The following is a description of a gene set: Human Gene Set: REACTOME_FATTY_ACIDS_BOUND_TO_GPR40_FFAR1_REGULATE_INSULIN_SECRETION Fatty Acids bound to GPR40 (FFAR1) regulate insulin secretion species: Homo sapiens, and this is the list of marker genes: GNA11, PLCB2, GNAQ, GNA15, PLCB3, PLCB1, FFAR1, GNA14